The following is a description of a gene set: studied in species Homo sapiens Human Gene Set: GOMF_NAD_P_H_OXIDASE_H2O2_FORMING_ACTIVITY Catalysis of the reaction: NAD(P)H + H+ + O2 = NAD(P)+ + hydrogen peroxide., and this is the list of marker genes: DUOX2, DUOX1, MICAL1, PYROXD1, AIFM1, MICAL2, CYB5R4 (NCBI Gene Id 51167), FMO5 (NCBI Gene Id 2330), KMO, NOX4